Given this list of marker genes Nek11, Crcp, Nmrk2, Gcn1, Washc1, Adipoq, Dguok, Itpkb, Zap70, Pmp22, Gk2, Insr, Pan3, Amhr2, Polr2l, Sbk3, Nmnat2, Selenoi, 4921509C19Rik, Ankrd42, Dbf4, Poli, Taok3, Pik3r2, Map2k7, Ccnd1, Akt3, Pkig, Fes, Cask, Mapk8, Clk4, Taok2, Prkag2, Tnk1, Polr1a, Rplp1rt, Tex14, Ip6k3, Bmp4, Akap11, Gskip, Egfr, Pik3ip1, Prkg1 (protein kinase, cGMP-dependent, type I), Itpka, Art5, Prkcq, Dazap2, Pak6, Ltf (lactotransferrin), Pck1, Erbb4, Epha5, Hk2, Insrr, Pik3c2b, Bmpr2, Cdk4, Wnk3, Gm14151, Trim28, Raf1, Cdk2, Tnk2, Prkab2, Pik3r3, Alkal1 (ALK and LTK ligand 1), Mylk2, Cpne3, Ern2, Ccnt2, Nrk, Cdc42bpg (CDC42 binding protein kinase gamma), Polr3a, Trib3 (NCBI Gene Id 23913), Nme4, Irs1, Stk36, Jak2, Grem1, Ccnf, Stk17b, Qars1, Phkg1, Sgk1, Gars1, Nudt5, Elp4, Pgs1, Bmp2, Ccng2, Dgkk, Nek5, Prkcd, Ankrd54, Sephs2, Prps2, Rps6kc1, Lilrb4b, Als2, Ryk, Prps1l3, Pinx1, Map2k2, Cdkn2b, Ccnd3, Gk5, Cdk5r2, Csnk2b, Pold3, Epha7, Mob3a, Met, Gnptg, Map3k2, Fer, Rhoh, Ulk3, Trpm6, Prex2, Art4, Irgm2, Atad3a, Trib1, Mvk, Tk2, Flt1, Nek3, Prkrip1, Ctu2, Tgfa, Gsk3b, Ccnjl, Tgfbr2, Fn3k, Chek2, Cgas, Parva, Papss2, Dgkg, Sav1, Nck1, Sgms2, Tent2 (terminal nucleotidyltransferase 2), Src, Ccnb1-ps, Mast2, Papolg, Map2k3, Ppp2r5a, Cdk10, Hspa5, Cav1, Cerkl, Rptor, Stkld1, Ror1, Grk3, Spred1, Vegfa, Npr1, Dab2ip, Prkaca, Mast3, Prag1, Smcr8, Oas1c, Ptk2, Tut1, Npm1, Dele1, Trim24, Cd40lg, Ptges3, Kars1, Ccl8, Rock2, Rgcc, Axl, Grk4, Parp1, Sbk2, Polr2g, Fkrp, Ephb6, Ccdc88a, Tut7, Stk32a, Csnk1d, Mst1r, Map3k12, Dolk, Haspin, Uckl1, Sirt6, Mknk1, Parp16, Nme7, Galk1 (galactokinase 1), Tep1, Rubcn (RUN domain and cysteine-rich domain containing, Beclin 1-interacting protein), Nrg2, Prkra, Snrk, Nme3 (NCBI Gene Id 79059), Hipk2, Prkg2, Araf, D1Pas1, Parp9, Gprc5d, Csnk1g1, Ywhab, Tefm, Pfkm, Mapk9, Ikbke, Ankle2, Camk2a, Bcr, Prkaa2, Chp1 (calcineurin-like EF hand protein 1), Gucy2e, Pgk2, Stk4, Riok1, Smok2b, Cdkl1, Ins2, Tent5a, Chek1, Sik3, Mlkl (mixed lineage kinase domain-like), Abl1, Rheb, Cept1, Pikfyve, Map2k1, Papola, Cdkl2, Igtp, Smok2a, Klf4, Pik3cb, Mst1, Inka1, Calm2, Rplp1, Pik3c2a, Gnptab, Ccni, Sgms1, Cdkn1a, Prkaa1, Mink1, Polr2b, Acd, Lmtk2 (NCBI Gene Id 72890), Nagk, Ranbp2, Tesc, Pik3r5, Mylk4, Tkfc, Hkdc1, Tbck, Art1, Map4k1, Pik3r1, Mark2, Alkal2, Lrrk2, Adpgk, Prkar1a, Btk, Dyrk1a, Akt1s1, Ins1, Pkn1 (protein kinase N1), Rps6kl1, Apc, Tcl1b4 (T cell leukemia/lymphoma 1B, 4), Sgk2, Chka, Cks1b (CDC28 protein kinase 1b), Ankk1, Ptk6, Tgfbr3l, Mab21l1, Mapkapk2, Map3k9, Pstk, Pdgfra, Scyl2, Rbks, Dapk2, Daxx, Flad1, Rngtt, Cdk6, Nme2, Gphn, Malt1, Cab39l, Mak, Csnk2a1, Polr1d, Aurkb, Alpk3, Map3k8, Polm, Coasy, Pde8a, Adck2, Pot1b, Map2k5, Ccne1, Mapk1, Mast4, Pgk1, Pnck, Rev3l, Cdk13, Map2k4, Cdkn1b, Dus2, Bckdk, Chpt1, Tesk2, Plk1, Nckap1l, Kidins220, Prkar1b, Sik1, Fktn (NCBI Gene Id 246179), Map3k14, Tnks2, Cit, Prex1, Prkar2b, Dyrk2, Parp10 (NCBI Gene Id 671535), Itk, Polr3k, Polr2h, Spry4, Mapk10, Mup3 (NCBI Gene Id 17842), Erbb2, Lats2, Csf1r, Aurka, Dck, Ghrl, Fyn, Efemp1, Rack1, Art2b, Stk25, Abl2, Oas2, Mcrs1, Nek7 (NIMA (never in mitosis gene a)-related expressed kinase 7), Dyrk3, Map3k21, Nos2, Prkab1, Baz1b, Areg, Scyl3, Mapk8ip2, Wnt11, Acsl1, Dmpk, Egf, Lrguk, Gak, Tcl1b1, Uap1, Polr2f, Atr, Tssk5, Cdk16, Hipk3, Ror2, Atm, Stk40, Fam20a, Scyl1, Parp8, Pola2, Stk32c, Prkcz, Srms, Rskr, Ak2, Dkc1, Ccnj, Mapkapk5, Nrbp2, Cdk5 (cyclin dependent kinase 5), Pcyt1b, Pfkl, Nme5, Dgkz, Stk-ps2, Mob3b, Nrg1, Ckmt1, Gucy2g, Gucy2f, Elp3, Dgkq, Lyn, Polh, Oas1g, Pklr, Fgr, Terf2, Rassf2, Lrp6, Aatk, Peak1, Polb, Plk5, Mastl, Vrk1, Polg, Bmp7, Lats1, Erbb3, Ccnq, Pigg, Nmnat3, Pak3, Tcl1 (T cell lymphoma breakpoint 1), Irak2, Uhmk1, Pim2, Map3k1, Lilrb4a, Aak1, Csnk1e, Ttbk2, Ajuba, Pot1a, Gucy2c, Art2a, Pi4kb, Pip4k2a, Nek8, Hexim1, Tent5d, Ak5, Tiparp, Lamtor3, Wee2, Gm17949, Pik3cd, Flt3, Pank2, Glyctk, Dcakd, Cks2, Twf1, Ten1, Cdc42bpa, Cdkn2d, Tssk2, Phkg2, Cep43, Nol9, Myo3b, Cdk11b, Prkcb, Map4k4, Dyrk1b, Yes1, N4bp2, Grm5, Cdk19, Pkn3, Nmrk1 (NCBI Gene Id 225994), Camkk2, Mob2, Kit, Dntt, Trpm7, Galk2, Polr3b, Camk2g, Epha1, Mob3c, Camk2b, Cdipt, Pik3r4, Ip6k2, Pdk1, Cmpk1, Rad50, Tie1, Deptor (DEP domain containing MTOR-interacting protein), Pank4, Mapkapk3, Stk33, Fastk, Itprip, Ly6g6e, Strada (NCBI Gene Id 77993), Samd8, Pak1ip1, Prkacb, Dyrk4, Pkia, Tk1, Tssk1, Slc27a1, Sh3glb1, Ckm, Jak3, Mup2, Trp53rka, Ccnb2, Flt4, Ppip5k2, Nadk2, Rev1, Map3k19, Ccno, Cdk9, Htr2a, Ckb, Pim3, Brsk2, Cert1 (ceramide transporter 1), Mark1, Mapk12, Etnk2, Irak3, Nek10 (NIMA (never in mitosis gene a)- related kinase 10), Blk, Cdk5r1, Crppa, Tent5c, Riok2, Gprc5b, Ephb1 (NCBI Gene Id 270190), Pi4k2b, Cilk1, Stk38l, Cks1brt, Gdpgp1, Pip4k2b, Ptk7, Epo, Cdk14, Iqgap1, Pfkp, Stk35, Rac2, Pcna, Pip5k1c (NCBI Gene Id 18717), Prkd3, Gdf2, Tcl1b2, Hyal2, Irak1, Ccna2, Musk, Oas1a, Tyk2, Crls1, Hbegf (heparin-binding EGF-like growth factor), Uap1l1, Dclk3, Obscn, Parp14, Nme1, Stk24, Mup4, Mertk, Mmd, Mmd2, Map3k20 (NCBI Gene Id 99253), Polr3c, Tcl1b3, Clp1, Cdkn2c, Hipk1, Cdk12, Oasl1, Ak7, Mapk4, Irs3, Ptk2b, Atg13, Ulk4, Pdk3, Ptdss1, Cdk17, Prkce, Dtymk, Wdr81, Map4k2, Pak2, Spry2, Trio, Pkm, Macroh2a1, Terf1, Stk19, Pif1, Camk2d, Cd24a, Fcsk, Dusp19, Hjv, Mapk6, Pdk2, Sgk3, Cdkl5, Eef2k, Polr2j, Melk, Hunk, Tcl1b5, Braf, Hspb1, Agk, Ip6k1, Oas1f, Pgm2l1, Map3k15, Dgki, Tnik, Fhit, Cdk1, Pip5kl1, Pi4ka, Samd15, Tbk1, Ccnb1, Camk1, Fam20b, Pals1, Acvr2a, Wnk4, Idnk, Tek, Rfk, Dgkb, Tsacc, Mtpap, Pip5k1b, Adck5, Ephb4, Prkag3, Map3k10, Ntrk3, Ulk2, Nuak2, Tamm41, Ntrk1, Prkca, Srpk3, Map3k6, Ccna1, Nolc1, Stk39 (serine/threonine kinase 39), Chrac1, Nadk, Htatip2, Tut4, Csnk1a1, Frk, Ccnl2, Polr2i, Etnk1, Tlk1, Nek6, Lmtk3, Adk, Gucy2d, Tesk1, Ppip5k1, P2rx7, Selenoo, Pcyt1a, Pfkfb2, Tert, Coq8a, Blvra, Nim1k, Mtcp1 (NCBI Gene Id 547409), Prps1l1, Ccnt1, Acvr1c, Mstn, Clk2, Dgkd, Nek2, Mylk, Ksr2, Tgfbr3, Camk4, Pigf (phosphatidylinositol glycan anchor biosynthesis, class F), Hsp90ab1, G6pc1, Mup11, Adck1, Avp, Trnt1, Mt3, Jak1, Mapk3, Pdxk, Prkcg, Pnpt1, Rnasel, Map3k3, Nek4, Coq8b, Rps6kb1, Ptges3-ps, Prkch, Mocs3, Poll (polymerase (DNA directed), lambda), Smg1, Trib2, Ak4, Igf1r, Hexim2, Polk, Srpk2, Ikbkb, Dclk1, Camk1g, Cdk3, Papss1, Map3k7, Gsk3a, Cmpk2, Pi4k2a, Mup5, Tent5b, Mapk13, Plk4, Ccnh, Prkci, Gys1, Chkb, Angpt4, Ripk2, Stk38, Ephb3 (Eph receptor B3), Ercc6, Hk3, Bmpr1b, Map3k13, Taf1, Thg1l, Galt, Htra2 (HtrA serine peptidase 2), Camk1d, Srpk1, Cmas, Wdr91, Cdk15, Prkdc, Ccnc, Dusp22, Alk, Tnks, Ripk3, Gckr, Etaa1, Map3k5, Grk1, Oas1h, Stk3, Grk5, Gprc5c, 1810024B03Rik, Spdya, Cds1, Akt1, Pak5, Pik3c2g, Tgfbr1, Mok, Ddr2, Parp4, Epha4, Map2k6, Ccl5, Kat2b, Rps6ka1 (NCBI Gene Id 230803), Mapk15, Mark3, Mast1, Mark4, Limk2, Gprc5a, Bcl10, Pank1, Calm3, Uck2, Myo3a, Xylb, Gm4922, Kdr, Hipk4, Epha2, Ccnk, Cdc37, Rps6kb2, Cdkl3, Ros1, Eif2ak1, Fgfr1, Itpk1, Acvrl1, Ctu1, Hk1, Styk1, Ereg, Stradb, Cdk18, Tec, Rps6ka6, Cdkn2a, Polr1h, Gstp1, Sephs1, Rpap1, Cdk7, Parp6, Nek9, Dgke, Ahsg, Mapk7 (mitogen-activated protein kinase 7), Dgka, Itsn1, Aldh18a1, Nrbp1, Pak1, Grk2, Prkx, Tlk2, Fggy, Nlk, Pak4, Rock1, Wnk2, Pbk, Gm7358, Rps6ka3, Mnat1, Pskh1, Ak8, Prkd2, Pigo, Epha6, Tex24, Pold1, Tab1, Eif2ak3, Cab39, Terc, Ugp2, Vrk3, Ulk1, Sirt4, Pip4k2c, Alpk2, Stap1, Pdk4, Riok3 (NCBI Gene Id 66878), Elp1, Matk, Ciita, Inca1, Ccng1, Pask, Prkar2a, Pink1 (NCBI Gene Id 68943), Ppp1r9b, Oas1d, Polr2e, Guk1, Aurkc, Pip5k1a, Stk31, Polr3h (NCBI Gene Id 78929), Mapk14, Pik3r6, Irs2, Csnk2a2, Eif2ak2, Camkk1, Tom1l1, Uprt, Cdk20, Pnkp, Tpk1, Rps6ka2, Camkv, Mup1, Sik2, Ippk, Spred2, Npr2, Cds2, Ptdss2, Map3k11, Cnppd1, Rps6ka5, Ksr1, Acvr2b, Syk, Brd4, Sbk1, Speg, Dgkh, Pkib, Ntrk2, Pmvk, Smo, Shpk, Sh3bp5, Smok3a, Camk2n2, Mb21d2, Ripk4, Inka2, Parp3, Ccnl1, Ephb2, Hykk, Pfkfb4, Irgm1, Tssk3, Irak4, Pfkfb3, Pign, Stk16, Ltk, Stk26, Pkdcc (NCBI Gene Id 13934), Ilk, Mob1b, Oas1e, Nt5c2, Ak1, Oasl2, Clk1, Oxsr1, Csk, Cdkl4, Gne, Pola1, Fgfr3, Ccne2, Polr2a, Tssk6, Dapk1 (death associated protein kinase 1), Pdgfrb, Rps6ka4 (NCBI Gene Id 68884), Socs1, Plk2, Ngf, Prkd1, Parp12, Txk, Epha3, Il6st, Ddr1, Acvr1, Alpk1, Grk6, Ern1, Ak9, Pxk, Hmgb1, Fpgt, Papolb, Uck1, Oas3, Bub1b, Fam20c, Akt2, Polr1c, Trp53rkb, Wars1, Pim1, Pik3c3, Ednra, Ttn, Taok1, Ccl3, Eif2ak4, Acvr1b, Lgals9, Trem2, Art3, Wee1, Polr2c, Fermt2, Aasdhppt, Dpagt1, Afap1l2, Ficd, Brd2, Tssk4, Gmppb, Casp3, Khk, Nuak1, Cdk8, Camk2n1, Pank3, Pik3cg, Pold4, Polq, Polrmt, Igf2, Ripk1, Prpf4b, Pole, Pcyt2, Polr1b, Abi1, Gm7168, Cdc42bpb, Mlst8, Nmnat1, Pdik1l, Chuk, Mtor, Lck, Nrp1, Fgfr2, Bmpr1a, Stk32b, Btc, Prkag1, Hck, Ddx3x, Gk (glycerol kinase), Igf1, Dapk3, Cad, Polg2, Rictor, Socs3, Bccip, Ipmk, Ibtk, Dstyk, Mylk3, Gck, Gykl1, Fgfr4, Primpol (NCBI Gene Id 408022), Polr2k, Clk3, Pals2 (protein associated with LIN7 2, MAGUK family member), Tnni3k, Smok3c, Epgn, Stk11, Brsk1, Slk, Cib1, Map4k5, Ret, Tent4b, Mapk11, Nme6, Pkn2, Csnk1g3, Ccny, Prps1, Ttbk1, Tgfb1, Itpkc, Stk10 (serine/threonine kinase 10), Pik3ca, Dnajc3, Vrk2, Mknk2, Ckmt2, Fgf13, Gm7356, Calm1, Sphk2, Vac14, Epha10, Cerk, Pkmyt1, Tyro3, Atg14, Nbn, Bmp2k, Sostdc1, Poln, Oas1b, Agap2, Ccnb3, Fgfrl1, Socs5 (suppressor of cytokine signaling 5), Topbp1, Ptprc, Trpt1, Cdkn1c, Mbip, Eef1a1, Pdpk1, Prim1, Nek1, Ppef2, Bmx, Ttk, Plk3 (polo like kinase 3), Top1, Nrp2, Dclk2, Csnk1g2, Limk1, Ak3, Fn3krp, Wnk1, Yrdc, Smok3b, Parp11, Sh3bp5l, Map3k4, Tent4a, Ak6, Dcaf1, Sphk1, Parp2, Map4k3, Bub1, Lrrk1, Ccnd2, Cdc7, Mos, Mob1a, Pomk, Epha8, Kalrn, Pfkfb1, here is a description of the gene set: Catalysis of the transfer of a phosphorus-containing group from one compound (donor) to another (acceptor). Mouse Gene Set: GOMF_TRANSFERASE_ACTIVITY_TRANSFERRING_PHOSPHORUS_CONTAINING_GROUPS species: Mus musculus